The following is a description of a gene set: The process of targeting specific proteins to particular regions of the cell, typically membrane-bounded subcellular organelles. Usually requires an organelle specific protein sequence motif. studied in species Mus musculus Mouse Gene Set: GOBP_PROTEIN_TARGETING, and this is the list of marker genes: Tomm22, Trmt10b, Gsk3a, Tomm40, Rtp1, Ywhab, Vps37c, Mtcl1, Cib1 (NCBI Gene Id 23991), Pmpca, Tram2, Usp17le, Golga7, Bcap31, Hgs, Bnip3l (NCBI Gene Id 97931), Tent2, Bag6, Sgtb, Zdhhc20, Vps51, Kcne1, Hras, Timm23, Srp72, Arxes2, Ndufa13, Mlph, Sqstm1, Pikfyve, Ap3d1, Mtch1, Get4, Srebf1, Chp1 (NCBI Gene Id 80510), Ccl2, Mon1b, Zdhhc21, Man1a, Gcc2, Zdhhc24, Aqp11, Spcs1, Arl6, Ndp, Romo1, Mief2, Cacng3, Hpca, Atg14, Aifm1, Fis1, Hspa5, Chmp4b, Ap4m1, Clu, Zdhhc1, Hspa8, Zdhhc23, Kcnb1, Parl, Timm50, Snx16, Zdhhc19, Timm44, Immp1l, Grin2a, Vps37b (vacuolar protein sorting 37B), Pmpcb, Srp19, Zfand2b, Sec63, Glp1r, Vps13d, Golph3, Herpud1, Srp54b (NCBI Gene Id 665155), Vps13c, Ank3, Cwh43, Arpc2 (actin related protein 2/3 complex, subunit 2), Syngr2, Hsp90aa1, Pdzk1, Large1, Bag3, Rtp2, Zdhhc25, Pard3, Srprb, Lrrk2, Hspa1l, Timm8a1, Edem1, Syngr1, Timm13, Mief1, Spcs3, Laptm5, Zdhhc14, Tomm20, Ywhaz, Sgta, Prnp, Vps4a, Rhod, Dnlz, Samm50, Ap3b1, Arl6ip1, Pam16, Dusp21, Hap1, Ogt, Mterf4, Bag4, Sec61a1, Srp14, Slc1a1, Srp9, Fyn, Timm9, Bloc1s6, Aip, Lamp2, Hspd1, Exoc4, Zdhhc11, Srp54c, Kcnq3, Stxbp4, Synj2bp (NCBI Gene Id 28115), Ncoa4, Stom, Tomm20l, Zdhhc2, Nlgn1, Nacad, Vps41, Dmtn, Dusp18, Pink1, Rab3ip, Gga3, Mon1a, Tram1, Nup54, Tomm40l, Zdhhc12, Pex16, Ankrd10, Timm22, Zfand6, Adora1, Grpel1, Siah3 (siah E3 ubiquitin protein ligase family member 3), Irgm1, Vps52, Hspa4, Zfyve16, M6pr, Inpp5k, Myo1c, Yif1b (NCBI Gene Id 77254), Micall1, Vps13a, Trak1, Trak2, Pik3c3, Rtp4, Pak1, Mgarp, Tram1l1, Timm21, Pex7, Zdhhc6, Adcy10, Cdkn2a, Ubl4a, Macf1, 4930550C14Rik, Hacl1, Zfand2a, Hps4, Timm29, Mfn2, Itgam, Zdhhc4, Pick1, Fbxw7 (F-box and WD-40 domain protein 7), Timm17b, Zdhhc22, Tomm70a, Cemip, Gfer, Slc51b, Vps8, Cdk5 (NCBI Gene Id 12568), Cacnb3, Dnajc15, Zdhhc3 (zinc finger, DHHC domain containing 3), Vps37d, Spcs2, Vps37a (vacuolar protein sorting 37A), Pdcd5, Zdhhc7, Sec61b, Pex6, Pik3r4, Tcaf1, Fbxo7, Cacnb1, Rabgef1, Sirt4, Oga, Get3, Rpl11, Irgm2, Chchd4, Get1, Lhcgr, Scarb2, Bid, Ptpn5, Nedd4, Sort1, Gdi1, Gdap1, Ppp2r2b, Immp2l, Timm17a, Nol3, Golga7b, Asb3, Pan3, Srp54a, Timm10, Prkaa1, Gipc1, Golph3l, Lonp2, Pdcd5-ps, Tomm5, Naca, Chm (CHM Rab escort protein), Dnajc19, Igtp, Grpel2, Gnptab, Mff, Ywhaq, Rtp3, Lyset, Akt2, Srp68, Pml (promyelocytic leukemia), Ap4b1, Folr2, Zdhhc15, Agk, Erbin, Myo6, Cdk5r1, AU015836, Gbp2, Pex19, Cacng2, Arxes1, Nbea, Zdhhc18, Ankrd6, Pex5, Tomm7, Vps54, Sec61a2, Itgb1bp1, Srpra, Becn1, Vps53, Zdhhc9, C2cd5, Smurf1, Mtch2, Os9, Asb15, Sec62, Ssr3, Nrarp, Pex1, Tomm34, Ppp1r3c, Ywhag, Sec61g, Mipep, Actr3, Ywhae, Ncf1, Rab7, Sorl1, Ap1s3, Nucb1, Atp5if1, Erbb2, Gbp5, Folr1